Given this list of marker genes OGDH, PRDX1, MT-TW, MT-ND1, FXN, MT-TV, MT-ND5, FH (fumarate hydratase), MMACHC, MT-ND6, MT-TK, MT-TL1, MMADHC, MMAA, MT-ND2, MT-ND3, MT-ND4, MT-ATP6, MMAB, here is a description of the gene set: Abnormality of Krebs cycle metabolism Human Gene Set: HP_ABNORMALITY_OF_KREBS_CYCLE_METABOLISM studied in species Homo sapiens An abnormality of the tricarboxylic acid cycle.